The following is a description of a gene set: Here we show that tumor necrosis factor (TNF) induced in human T-regulatory cells (Treg), as compared to conventional T cells (Tcon), a transcription program highly enriched for typical NF-κB target genes, such as: the cytokines LTA and TNF; the TNF-receptor super family members FAS, 4-1BB and OX-40; various anti-apoptotic genes; and other important immune-response genes. As an initial approach to examine the cellular program induced by TNF in Tregs versus Tcon cells, we employed microarray gene expression analysis at 2 and 24 hrs following TNF treatment. from publication Nagar M, Jacob-Hirsch J, Vernitsky H, Berkun Y, Ben-Horin S, Amariglio N, Bank I, Kloog Y, Rechavi G, Goldstein I (PMID 20181891) Human Gene Set: GSE18893_TCONV_VS_TREG_2H_CULTURE_UP species: Homo sapiens Genes up-regulated in lymphocytes treated with medium for 2h: T conv versus T reg cells., and this is the list of marker genes: RNF146, LMO1, GAB2, KXD1, AP2S1, SCNN1A (NCBI Gene Id 6337), RASSF8, DUSP10, TTC33, SDHAF2, TCEAL9, ARID5A, GTPBP6, CCSER2, TMEM167B, RSU1, GKAP1, CASP6, IL15, PQBP1, DNAJC1, C12orf43, CENPN, TMEM50A, DDI2, MYBPC3, MAP3K21, AKTIP, NADK, CDK11B, ADAMTSL2, PGM2 (NCBI Gene Id 55276), RABEP2, ACSL3, APLNR (apelin receptor), UXT, SURF1, SLC38A10, ANKMY2, STX8, PPIL4, CRACD, HSPB9, MACROH2A1, MLLT6, RNF19B, HOXB4, MRPL41, PNKD, DNAL1, ZNF572, HLCS, KLHL6, WDR24, IRF2BP1, UBE3B, USP4, SPRR2F, SAA2, PAQR8, NBEA, IFT46, CHCHD7, BRWD1, ZNF292, ARMCX3, EPAS1, FOXRED2, EFCAB14, FUNDC1, FNBP1, SPATA2L, BEX3, VPS35L, DMAC2L, UBXN6, IPO9, ALKBH7, ULK2, DHX30, C19orf67, ABHD5, CHD8, CCNDBP1, SETDB1, DUS3L, COX4I1, HCST, PPA2, PHF20L1, PI4K2B (NCBI Gene Id 55300), FUT7 (fucosyltransferase 7), FAM210B, ZNF771, LMBRD1 (NCBI Gene Id 55788), NUDT3, GADD45G (NCBI Gene Id 23575), IMMP1L, INPP5B, ZDHHC2, IKBKB, CEP152, DMAC2, USP31, EEF1G, ACADSB, CLU, NUDT9, CELF1 (NCBI Gene Id 10658), REXO4, GNGT2, RASA1, CD79B, ARK2C, NHERF2, AEBP2, SLC16A6, SREK1, TPCN2, HVCN1, TMEM258, YWHAH, PAF1, PHF6, LNPEP, PITHD1, PFDN5, BBX, ZBTB2, DTNA, TNIK, ARMC6, MTOR, VPREB1, DTX2, TENT5A (terminal nucleotidyltransferase 5A), PALS1, LRRC28, CLK3, RHOQ, TMEM160 (transmembrane protein 160), CD300LF, CYB5A, OLFML1, PRPSAP2, CFAP263, MRPS6, FAM177A1, FMNL2, EBI3, ERLEC1, LYPLA1, TGFBI, PDHA1, MGAM, IL22RA2, IL12A, PLEKHF1, HYPK, TPGS2, HIGD1B, TBPL1, FLOT1, MAP3K8, UBA3, ZC2HC1A, ALKBH3, DNAJC3, CERS6, RPL3, PRELID2, RRP36, ZHX3, MOB3C, ZBTB18, RSPH3, NXF1, SSH1, RAB2B, FKBP1A, LIAS, BSCL2, OMA1, MRPL19, DRAM1 (NCBI Gene Id 55332), ZNF32, IPO11 (importin 11), POLA2, SGK3, ACO1, MMUT, GNB3, MCUR1, CD247, ATP5F1E, NDUFS3, INIP, OTULINL, NAXE (NAD(P)HX epimerase), ARHGDIA